Given this list of marker genes CUBN, DHFR, TCN2, FTCD, SLC46A1, OTUD5, ZNF699, HLA-DQB1, SLC19A1, MTR, HLA-DQA1, here is a description of the gene set: Human Gene Set: HP_ABNORMAL_BLOOD_FOLATE_CONCENTRATION studied in species Homo sapiens Any deviation from the normal concentration of folate in the blood circulation. Abnormal blood folate concentration